Given this list of marker genes ACP5, CFP (NCBI Gene Id 5200), IFI35, ILK, ARPC4, ARHGAP25, ID2, CD72, here is a description of the gene set: Genes down-regulated in P493-6 cells (Burkitt's lymphoma) induced to express MYC. studied in species Homo sapiens The proto-oncogene c-myc (myc) encodes a transcription factor (Myc) that promotes growth, proliferation and apoptosis. Myc has been suggested to induce these effects by induction/repression of downstream genes. Here we report the identification of potential Myc target genes in a human B cell line that grows and proliferates depending on conditional myc expression. Oligonucleotide microarrays were applied to identify downstream genes of Myc at the level of cytoplasmic mRNA. In addition, we identified potential Myc target genes in nuclear run-on experiments by changes in their transcription rate. The identified genes belong to gene classes whose products are involved in amino acid/protein synthesis, lipid metabolism, protein turnover/folding, nucleotide/DNA synthesis, transport, nucleolus function/RNA binding, transcription and splicing, oxidative stress and signal transduction. The identified targets support our current view that myc acts as a master gene for growth control and increases transcription of a large variety of genes. Human Gene Set: SCHUHMACHER_MYC_TARGETS_DN from publication Schuhmacher M, Kohlhuber F, Hölzel M, Kaiser C, Burtscher H, Jarsch M, Bornkamm GW, Laux G, Polack A, Weidle UH, Eick D (PMID 11139609)